The following is a description of a gene set: Any process that modulates the frequency, rate or extent of the centrosome cycle, the processes of centrosome duplication and separation. Human Gene Set: GOBP_REGULATION_OF_CENTROSOME_CYCLE studied in species Homo sapiens, and this is the list of marker genes: CHMP5, CHMP2A, AURKA, NPM1, ATF5, TRIM37, CENATAC, PKHD1, CEP295, WDR62, XRCC3, PDCD6IP, CHMP4C, RAB6C, CHMP4B, SPICE1, SASS6, NUBP1, CEP120, MARK4 (microtubule affinity regulating kinase 4), VPS4B, STIL, CCNL2, XPO1, MCPH1, CEP76, CHORDC1, CCDC15, POC1B, GEN1, NUP62 (nucleoporin 62), SIRT1, CDK11B, BRCA1, ROCK2, ALMS1, CEP131, KAT2A, CCNF, CHMP1A, CHMP3, CHMP2B, CDK5RAP2, NAT10, TMEM67, POC1A, PLK2, KAT2B, CHMP1B, CEP295NL, FBXW5, RBM14, CCNL1, CENPJ, PLK4, C10orf90, PPP1R35, CDK11A, MDM1